Given this list of marker genes Il17a, Plcg2, Clec7a, Il17ra, Myd88, Csf2, Ifng, here is a description of the gene set: Any process that activates or increases the frequency, rate, or extent of interleukin-23 production. Mouse Gene Set: GOBP_POSITIVE_REGULATION_OF_INTERLEUKIN_23_PRODUCTION studied in species Mus musculus